The following is a description of a gene set: Mouse Gene Set: GOBP_NEGATIVE_REGULATION_OF_VIRAL_LIFE_CYCLE Any process that stops, prevents or reduces the frequency, rate or extent of viral life cycle. species: Mus musculus, and this is the list of marker genes: Ark2n, Trim15, Bst2, Ppia, Csnk2b